Given this list of marker genes YARS1, RPS18P9, SYNE1, ITGAX, SFXN1, BCYRN1, MBTPS1, FAN1, PLXND1, MECOM, NCF1B, L3MBTL2, NRIP2, TYMP, C1orf174, ARHGAP4, PJA1, WASHC1, SLC9A3-OT1 (SLC9A3 3' UTR overlapping transcript 1), WASH3P, APOE, STAB1, here is a description of the gene set: species: Homo sapiens from publication Gao S, Yan L, Wang R, Li J, Yong J, Zhou X, Wei Y, Wu X, Wang X, Fan X, Yan J, Zhi X, Gao Y, Guo H, Jin X, Wang W, Mao Y, Wang F, Wen L, Fu W, Ge H, Qiao J, Tang F (PMID 29802404) Human Gene Set: GAO_LARGE_INTESTINE_24W_C6_SECRETORY_PROGENITOR